Given this list of marker genes TNRC6A, AGO4, AGO2, TNRC6B, AGO1, TNRC6C, AGO3, here is a description of the gene set: Post-transcriptional silencing by small RNAs studied in species Homo sapiens Human Gene Set: REACTOME_POST_TRANSCRIPTIONAL_SILENCING_BY_SMALL_RNAS